Given this list of marker genes TGM2, TMEM131L, LEPROTL1, RERE, CD38, C2CD2, PRMT3, CBFA2T2, RYK, FCER1G, CSK, ALDH5A1, HMGCL, DCAF8, VAMP5, NUDT3 (NCBI Gene Id 11165), YARS1, CCR2, PLCL2, FH, PLAAT4, ARF3, LY75, RAB13, CD40, MTMR11, IRF2, CLPP, POLRMT, BCKDHA, MNT, JUND, NPAT (nuclear protein, coactivator of histone transcription), BCKDK, GGPS1 (geranylgeranyl diphosphate synthase 1, NCBI Gene Id 9453), DCAF11, S100A8, PSMC5, STOM, RABGGTA, MR1, PRKX, PTPA (NCBI Gene Id 5524), P2RY14, POLB, HAX1, MAPK14, USP22 (ubiquitin specific peptidase 22), TAPBP, DIAPH2 (NCBI Gene Id 7989), KCTD17, HLA-DQA1, UBAC1, PIK3CG, HSD11B1, ZRSR2P1, PEX7, SCRN1, LTA4H, SART1, DHPS, SYT11, INPP5F, VWA5A, STAT1, MDM1, DNAJC11, SCAMP3, HYAL2, RPA3 (replication protein A3), SPHK2, TLR5, PSMB2, SNX19, ATP5MC1, FARSA, C1QB, GPR65, C2, SERPINA1, RTF1, MT1G, SLC7A7, MDN1, LGALS3BP, HLA-F, PSMB10, CCT7, RNF113A, GPX4, PSME2, PLCG2, CYB5A, AFG3L2, BRD3OS, NADK, IL2RG, C1R, MSL1, ITGB3BP, MED12, ZNF384, NDUFS2, PTP4A2, ATP5F1A, FSCN1, MRTFA, AIM2, HMGN4, PIGB, ZDHHC18, ARID4A, FGL2, HSF2, COX7A2, TARBP1, CFB, ZFP36L1, CTSH, MTMR1, MYO1F, PRIM2, CDC42EP2, EPRS1, PGAM1, LYL1, ARAP1, CHI3L1, DGCR2, MRPS18B, GSN, BTN3A3, WDR37, PTPN18, LAGE3, UVRAG, TADA3, UROS, ILK, TBC1D22A, MCRS1, MRPL9, SLC1A3, TREX1, CASP9, CD33, ATOX1, CAPG, PSMB6, TESK1, AKAP9, IDO1, PDE6D, SH3BP1, MT1A, SH2B2, TBC1D9, CYC1, IL18, NFATC3, RDH11, FOXO4, IGFBP4, AKR1A1, STAT6, KLHL21, BTN3A1, NDUFV1-DT, OGT, C5orf22, STK25, PSMB9, NDUFS8, GALE, MGAT1, PNPLA4, IKBKE (inhibitor of nuclear factor kappa B kinase subunit epsilon), TWF2 (NCBI Gene Id 11344), ASGR1, MT1F, GPD2, VOPP1, CLIC2, TNFRSF14, IER2, DOK1, SNRPA, XPNPEP1, CDK19, ZFP36L2, SLC6A12, XPOT, HLA-DQB1, CENPS, GOT2, CCL5, USP13, R3HDM2, DGKZ, PHB2, here is a description of the gene set: Genes up-regulated in CD4 T cells under germ free conditions: healthy versus arthritis (KRN model). studied in species Homo sapiens Human Gene Set: GSE22140_HEALTHY_VS_ARTHRITIC_GERMFREE_MOUSE_CD4_TCELL_UP from publication Wu HJ, Ivanov II, Darce J, Hattori K, Shima T, Umesaki Y, Littman DR, Benoist C, Mathis D (PMID 20620945) A general defect of GF K/BxN T cell proliferation response toward antigen motivated us to look for the impairment in GF K/BxN T cells that might leads to the low Ab production and reduced disease phenotype seen in GF K/BxN mice. To find the difference between GF and SPF K/BxN T cells in a broad and non-biased fashion, we performed gene-expression profiling of these cells using microarrays.